The following is a description of a gene set: Mouse Gene Set: TABULA_MURIS_SENIS_BROWN_ADIPOSE_TISSUE_MESENCHYMAL_STEM_CELL_OF_ADIPOSE_AGEING from publication Tabula Muris Consortium (PMID 32669714) studied in species Mus musculus, and this is the list of marker genes: Mta2, Ap1b1, Ppp1r2, Kdm1a, Dynlrb1 (NCBI Gene Id 99273), Anks3, Ndufv2, Mfap3, Fnta, Stub1, Hmox1 (heme oxygenase 1), Gal3st4, Srp14, Chd4, Smpdl3a, Lamtor2, Lsm2, H2ax, Lcmt1, Arhgdia, Rarres2, Srpk2, Gtf2a2, Med11, C1d, Cd63, Eif3h, Vti1b, Chd1, Sf3b2, Txndc12, Adnp, Sdc4, C1qtnf2, Ube2s, Gsto1, Ankrd11, Ldha, Bcl7c, Rab3il1, Asl, Cops3, Wdr59, Pkia, Psme1, Mafb, Zfp608, BC031181, Mrps15, Exoc3 (NCBI Gene Id 72678), Bnip3l, Uqcrc1, Coil, Prr13, Lefty1, Zfp36l1, Ide, Ctnna1, Brd3, Mylip, Smarcb1, Map2k2, Tmem120a, Rhoc, Polb, H3f3b, Rtcb, Fkbp2, Taok2, Lman2, Arpc4, Trir, Mrps24, Sumo2, Rab11b, Zfp511, Rnf5, Cbx3, Sptssa, H2-K1 (NCBI Gene Id 56628), Shisa5, Polr3gl, Cndp2, Dnajc3, Mrpl51, Fam89b, Ufl1, Ptges, Nsd3, Abhd16a, Tra2a, Nedd9, Ctc1, Thap2, Ppa2, Cdc42ep3, Ranbp1 (NCBI Gene Id 19385), Anp32a, Sh3glb1, Atp6v0b, Arl8a, Tmem11, Smc3, Pxn, Stbd1, Calhm2, Iscu, Nfe2l1, Msra, Ciao1, Exosc5, BC004004, Ier5l, Map3k2, Actr2, Tsen34, Idh3b, Ssr1, Ddah2, Nr3c1, Zfp935, Hmox2, Cr1l, Macrod1, Pgk1, Asap2, Agtpbp1, Diablo, Ckb, Slc45a4, Ap2m1, Ppie, Tex264, Plpp3, Slc25a4, Snx3, Ptms, Ptgs1, Trappc6b, Naaa, Mageh1, Skil, Hnrnpd, Atg101, Selenow, Pcnt, Pycr2 (NCBI Gene Id 69051), Ubb-ps (ubiquitin B, pseudogene), Pigc, Mlf2, Bcl10, Imp4, Ensa, Zfpl1, Irak4, Smad1, Hilpda, Tspan4, Txnrd1, Ctcf (NCBI Gene Id 270092), Zmat2, Commd2, Ndufaf8, Spry2, Hspd1, Ndufa4l2, Ccnl1, Fdx1, Cfap20, Kdm5c (NCBI Gene Id 399585), Ppp1ca, Polr2g, Arhgdib, Metrnl, Zfp512b, Psmd8, Selenok, Ndufv3, Nagpa, Tln1, Phlda3, Ino80e, Ggh, Nudt16, Tmbim1, Vwa1, Thoc7, Nagk, Rpl3, Tmed9, Nr4a1, Bub3, Dok1, Rnf215, Ube2v1, Myo9b, Cavin3, Hspa4, Mrpl32, Pdcd6 (NCBI Gene Id 18570), Pde6d, Samd8, Ifi35, Med28, Aldoa, Igsf3, Arpc1b, Mcmbp, Ube2e3, Ccs, Trp53bp1, Zfp36, C1qa, Tspan18, Pex14, Nt5c3b, Dexi, Ssbp4, Tpm3, Eif3f, Myl12a, Nsmce4a, Trf, Bex3, Dnajc19, Asap3, Cuta, Rab5b, Polr2e, Camk2n1, Ddhd2, Cript, Dguok, Spag7, Fxyd6, Map1lc3b, Nup107, Rab8a, Mir24-2, Jazf1, Vcf1, Ywhaz, Sh3bp1, Mtarc2 (mitochondrial amidoxime reducing component 2), Dnaja1, Slc39a14, Ubl7, Mgst1, Atp5pd, Trp53bp2, Rfc5 (NCBI Gene Id 76790), Ttc28, Efhd2, Mrpl41, Dnm2, Twf1, Pdcl3, Gabarapl1, Rack1, Dpysl2, Fundc2, Mocs2, Smim30, Ppp2ca, Tango2, Naa20, Gab1, Pfn1, Ap2s1 (NCBI Gene Id 232910), Adamts10, Spg21, Fuca1, Ufm1, Prelid3b, Aldh2, Gipc1, Tmem158, Rhoj, Far1, Gpr34 (G protein-coupled receptor 34), Ppil4, Snrnp70, Pold4, Pnrc1, Stat2, Ramp2, Ldhb, Erp44, Rab4b, Tubb6, Amfr, Park7, Slc29a3, Psmb2, Tex261, Mrpl28, Rnf7, Cytl1, Ndufs3, Calm2, Map4k5, Mtx2, Sdf2l1, Exosc4, Slbp, Mgll, Adm, Arf6, Stx18, Rrp36, Med13l (NCBI Gene Id 76199), Tmem109, Tcf4, Zswim4, Clic4, Sf3b4, Pdzd11, Oaz2, Snrpa1, Mpc1 (mitochondrial pyruvate carrier 1), Atp6v1f, Pkig, Tbc1d5, Kmt2e, Ctr9, Zzef1, Zfp830, Bri3bp, Spcs2, Slc35b1, Efnb1, Plekhf1, Irf1, Ccdc66, Snrpb, Igf1r (NCBI Gene Id 77773), Gnai2 (G protein subunit alpha i2), Pcyt2, Slc66a2, Snhg7, Dcps, Tnfsf12, Vapa (NCBI Gene Id 30960), Csnk1a1, Tgfb1i1, Apoe, Arl13b, Ncoa3, Cast, Srsf9, Fkbp15, Prdx2, Ctsz, Tmem205, Coq10b, Adh1, Znhit1, Edf1, Gpx8 (glutathione peroxidase 8 (putative)), Psmb10, Mcrs1, Tcf7l2, Abhd11, Cdk7, Tug1, Fnbp1l, Psmb9, Ndufa12, Fut11, Dnttip2, Hhip, H1f2, Ebna1bp2 (EBNA1 binding protein 2), Limd2, Cebpg, Rmdn3, Pycard, B3gnt2, Spen, Rab5c, Cxcl1, Tmem176a, Bsg, Ece1, Arl6ip1, Gnaq, Pi4k2a, Isca2, Penk, Aph1b, Trim26, Slc46a1, Pfdn2, Tmsb10, Rogdi, Aplp1, Tmed10, Mrpl12, Exosc8, Pqbp1, Jdp2, Tmem179b, Mtfr1l, Cby1, Selenbp1, Med25, Matn2, Manf, Cldn25 (claudin 25), Ssh2, Fcgrt, Ppp1r11, Tubb4a, Tradd, Cyp27a1, Cdkn1c, Tmem50a, Pi16, Emc10, Fxyd1, Timm23, Tbc1d10a, Tmem107, Swap70, Scn1b, Vps72, Lsp1, Zbtb7a, Tmem86a, Pkm, Usf2, Cebpzos, Tyk2, Gadd45g, Nherf2, Slc31a2, Srsf7 (NCBI Gene Id 60426), Hsbp1, Slc30a9, Psmd12, Ssr2, Timm17a, Meox1, Cd9, Tmed4, Hsd11b1, Cotl1, Arl4d, Mpv17, Hmg20a, Smim7, Txn2, Mcrip1, Slc39a3, Fam120a (NCBI Gene Id 218236), Acaa2, Smdt1, Krt15, Pcmtd1, Tmem176b, Klf7, Pim1, Lsm4, Zfx, Ndufs7, Chtop, Myl12b, Ifitm2, Iqsec2, Sdhc, Khk, Rab7b, Cnn2 (NCBI Gene Id 12798), Fgf18, Pde4b, Sfxn1, Ston2, Map1lc3a, Apba3, Ptov1, Zfp622, Phpt1, Rusc2, Cd81, Cnbp, Sys1, H2-D1, Ptma, Eef1d, C1qtnf12, Cep83, Txnl4a, Gstm1, Cystm1, Vdac2, Car8, Ddit3, Fkbp8, Plscr3, Grpel1 (NCBI Gene Id 79564), Rsrc2, Arl6ip5, Mn1 (NCBI Gene Id 634779), Setd7, Bin1, Ahsg, Ces1d, Gak, Elovl1, Lactb2, Rara, Ubp1, Nthl1, Mydgf, Npc2, Sft2d1, Adgra3, Sh3rf3 (SH3 domain containing ring finger 3), Npm3, Sri, Brd2, Calhm5, Dcun1d1, Ulk2, Cfl1, Sfr1, Fst, Eif3k, Ptpn14, Mrpl4, Ube2j1, Nt5c, Akr1a1, Tubb5, Yme1l1, Mea1 (male enhanced antigen 1), Wasl, Fdx2, Inmt, Gpx3, Atp6v0e, Fyco1, Atf5, Usp22, Use1, Ociad1, Alox5ap, Slc25a5, Ier3, Trappc4, Wbp2, Cd74, Ccl11, Igsf8, Cds2, Rrp7a, Arf1, Prkaa1, Narf, Tspan3, Lmo4 (NCBI Gene Id 16911), Mtch1, Hmgn1, Rmnd5a, Naa80, Ormdl2, Hibadh, Gnpda2, Cdc27, Atrx, Zfp638 (zinc finger protein 638), Gng10, Mapk1ip1l, Psmb8, Map2k3, Szrd1, Myh10, Ms4a4d, Mxra8 (NCBI Gene Id 74761), AW112010, Plekha5, Cers2, Tomm6, Abraxas2, Pfdn5, 4930453N24Rik, Tet2, Rnf126, Maf1, Nfkbib, Rbms1, Sumo3, Coq5, Hdac1, Ppp1r12b, Pcna, Cnep1r1, Emd, Atp5f1d (ATP synthase F1 subunit delta), Gnptg, Apod, Csrnp1, Pip4p1, Ebp, Dynll2, Ybx1, Tmem204, Emc4, Zfp414, Snai1, Lyz2, Sertad1, Cyb5r3, Lrrc8a, Gstt1, Fam171b, Sf3b1, Prepl, Emc8, Fam32a, Ddx50, Tut4, Ubxn4, Fis1, Nipsnap3b, Ppdpf, Rnf130, Setx, Zscan26, Cep20, Crip2, Ypel5, Sbds, Dhrs3, Zdhhc7, Eif3e, Eif3g, Mcfd2, Ppm1f, Gnb1 (guanine nucleotide binding protein (G protein), beta 1), H2-Ab1, Wdr33, Coro1b, Hmgn2, Hsd17b12, Atp5pb, Usp36 (NCBI Gene Id 72344), Rsrp1, Ncl, H2-Aa, Anxa7, Psma5, Ptpn2, Htatip2, Atp6v0c (ATPase, H+ transporting, lysosomal V0 subunit C), Gtf3c4, Mphosph10, Il17d, Mpg, Gpm6b, Gps2, Myl9, Tmem9, Dpm1, Plpp1, Slc25a3, Rassf1, Elof1, Cirbp, Srsf2, Atp6v1g1, Polr2c, Jkamp, Oaf, Pebp1, Gstm2, Cct3, Pa2g4, Cyp4b1, Esd, Fos, Psmc2, Btg2, Slc36a4, Ormdl3, Tfpt (TCF3 (E2A) fusion partner), Per3, Cmtm6, Sde2, Klf6, Tle5, Yif1b, Timp3, Atf4, Mycbp, Prdm2, Tax1bp3, Ncbp2, Ywhae (tyrosine 3-monooxygenase/tryptophan 5-monooxygenase activation protein, epsilon polypeptide, NCBI Gene Id 22627), Card19, Shfl, Lasp1, Mapk1ip1, Bmyc, Chmp2a, Cyb5a, Timm50, Prdx5, Fam210a, Syf2, Ivns1abp, Dnajb1, Psenen, Rusc1, Ptgr3, R3hdm2, Irf2bp2, Gatd1, Pik3c3, Ilk, Cdk10, Ift57, Babam1, Nabp2, Arl5b, Anapc11, Dlgap4, Ubn1, Gpx4, Sntb2, Kpna4, Psma1, Nudt16l1, Raly, Tuba4a, Cyb5r1, Tmem250, Nsmce3, Rundc1, Napa, Zfp800, Ostc, Ift27, Capg, Smim14, Pttg1, Thbs1, Srebf2, Med10, Eif1b, Clasp2, Abhd8, Slc50a1, Nbl1, Nfkbie, Dus3l, Malat1, Ndufa8, Oas1a, Ifi30, Pim3, Ftl1, Gabarapl2, Ndrg2 (NCBI Gene Id 29811), Cygb, Josd2, Dock7, Leo1, Emc7, Eif2b4, Camk1, Ngdn, Gstk1, Cdkn1a, Pole4, Dtnbp1, Maz, Ssna1, Pgp, Znhit3, Ccl2, Lag3, Hk1, Dgcr6, Pdf, Cald1, Bet1l, Itpripl1, Aip, Aplp2, Hnrnpr, Plvap, Snrpc, Snrpa, Commd7, Laptm4a, Nsg1, Necap2, Psmg2, Srsf5, Il33, Spr, Samd4b, Sharpin, Gadd45b, Ier2, Vamp8, Ptprb, Il10rb, Zftraf1, Pdgfrb, Hectd1 (NCBI Gene Id 320157), Dusp12, Adrm1, Tmem222, Plin2, Gpr108, Prkab1, Eif4b, Hras, Irf2bpl, Foxn3, Psmd4, Sar1b, Trappc3, Sting1, Rarg, Fxr2, Wbp1, Slc25a11, Phb2, H2-M3, H2-Eb1, Tmem234, Wasf2, Dazap2, Rpl13a, Sdhd, Nfic, Ndufa9, Spin1, Sparcl1, Snrnp40, Fkrp, Azi2, Ldaf1, Nr1h2, Lysmd2, Eif4ebp1, Pltp, Rala, Srek1, Sdf2, Bccip, Ginm1 (glycoprotein integral membrane 1), Skic8, Cenpx, Lrwd1, Slu7, Bag3, Sec13, Cxcl14, Hebp1, Tceal8, Smad7, Fdps, Ypel3, Socs1, Eif4h, Golga7, Selenom, Grina, Gstp1, 1110004F10Rik, Eif3i, Swi5, Zfand5, Oser1, Mettl27, Naxd, Cyba, Mdh2, Ak2, Cbr3, C1qbp, Psmb6, Keap1, Stat6, Krt8, Cycs, Pin1, Mapk3, Cbr1, Actr10, Ift172, Psma2, Ciapin1, Serpine2 (NCBI Gene Id 20720), Ccdc124, Eva1b, Tm2d1, Eif6, Clpp, Pcbp2, Pigx, Ftsj1, Tssc4, Tm4sf1, Eri1, Rdm1, Pnn, Lamtor5, Tsc22d1, Zwint, Txndc15, Tufm, Tmem160, Ebpl, Usp11, Prdx1, Tsn, Mff, Eif5a, Ppp4c, Psma3 (proteasome subunit alpha 3), Rbm26, Drap1, Phf2, Dhrs7, Bri3, Ndufb10, Rnaset2b, Chaserr, Rbm25, U2af1, Tcf7l1, Tkt, St6galnac4, Tmem126a, Arl6ip4, Plekha2, Hoxa5, Oaz1 (NCBI Gene Id 18245), Dcaf12, Pgd, Lias, Cyc1, Arhgef1, Cebpb, Ube2d-ps, Jund, Myd88, Lims1, Ncbp1, Coq10a, H2-T23, S100a16, G6pc3, Manbal, Khsrp, Cx3cr1, Wdfy3, Alyref, Sumo1, Rbm39, Srsf11, Msx1, Lamtor1, Mospd3, Cnpy3, BC028528, Emx2, Lama4, Akap9, Snx6, Fam107a, Alg14, Junb, Itgb1bp1, Cnih4, Gprasp1, Commd10, Apbb1ip, Zfp131, Farsa, Ar, Etfb, Xbp1, Senp6, Kdm6b, Rtl8c (NCBI Gene Id 72865), Susd2, Syvn1, Pcmt1, Steap3, Bckdha, Mdk, Prr5, Akap12, Adprs, Glmp, Acin1, Hsph1, Isoc1 (NCBI Gene Id 66307), Sin3b, 1810037I17Rik, Id2, Golm1, Lrp6, Agtrap, Zbtb21, Flnc, Cdk2ap2, Rhobtb3, Dgat1, Tor1a, Tra2b, Rras, Clic1, Yae1d1, Vwa5a, Cryab, Bud13, P2rx4 (purinergic receptor P2X, ligand-gated ion channel 4), Hdgfl3, Psip1, Mlx, Gemin7, Bloc1s1, Ninj1, Klf9